The following is a description of a gene set: Human Gene Set: GOBP_INTEGRIN_ACTIVATION species: Homo sapiens The aggregation, arrangement and bonding together of an integrin, a heterodimeric adhesion receptor formed by the non-covalent association of particular alpha and beta subunits, that lead to the increased affinity of the integrin for its extracellular ligands., and this is the list of marker genes: FERMT3, KIF14, RAP1B (RAP1B, member of RAS oncogene family), FN1, TLN1, SELP, CX3CL1, SKAP1, PIEZO1, CDH17, LRP12, FERMT1, FBLIM1, PTGER4, PLEK, MZB1, SRC, RASIP1, JAM3, CXCL12, P2RY12, KRIT1, CXCL13 (C-X-C motif chemokine ligand 13), FERMT2, ITGB1BP1, COL16A1, FARP2